The following is a description of a gene set: A process of protein insertion into the endoplasmic reticulum (ER) membrane in which stop-transfer membrane-anchor sequences become an ER membrane spanning helix. Mouse Gene Set: GOBP_PROTEIN_INSERTION_INTO_ER_MEMBRANE_BY_STOP_TRANSFER_MEMBRANE_ANCHOR_SEQUENCE studied in species Mus musculus, and this is the list of marker genes: Emc9, Emc2, Emc3, Emc8, Emc1, Emc6, Mmgt1, Emc7, Wnk1, Emc4, Emc10 (ER membrane protein complex subunit 10)